Given this list of marker genes NAB1, DCLK2, INCENP, EIF2AK2, NUF2, TOP2A, PLXNB2, PLK2 (polo like kinase 2), GAD1, TOX (thymocyte selection associated high mobility group box), HCK, EHD4, GRHL1, RAD54L, KNTC1, NDFIP2, KIF4A, BDH2, GPX8, CASP8, NCAPH, MYBL1, PDCD1, MICAL2, LAG3, IFITM3, DST, TTK, CKS1B, TLR7, MIS18BP1, STRC, IFI16, PHACTR2, PPIC, EPCAM, CMKLR1, CCNA2, MX2, ORAI3, CCDC146 (NCBI Gene Id 57639), TNFSF4, CCNB2, GCNT1, TJP2, EIF4E3, KIF15, BIRC5, CKAP2L, TXN, CLGN, HSPA4L, HERC5, SGO1, CDCA8, CCNF, ARHGAP11A (Rho GTPase activating protein 11A), TCF19, RAD51, CDCA3, RRM2, EOMES (eomesodermin), DRAM1, RAD54B, BUB1B, CASP4 (caspase 4), CCDC136, GPSM2, GRM8, ITIH5, CFB, TFDP2, PRELID2, CDKN3, DGKG (diacylglycerol kinase gamma), SHCBP1, IL10, TPX2, SGO2, NEIL3, CD38, KIF14, NDC80, CENPF, CCNYL1, TACC3, RYK, IKZF2 (NCBI Gene Id 51173), TRIM59, XCL1, TMEM210, PTMS, CLSPN, LRATD1, ADAP1, TRPS1, CEP55, HAVCR2, CDK1, DOCK7, CEACAM1, ANLN, RGS16, NCAPG2, PLOD2, HMMR, STX7, CHST12, CDC20, MKI67, MNT, FGL2, SERPINI1, EPC2, MSL3, PLSCR1, SRGAP3, STMN1, SETBP1, NEB, OCIAD2, TEAD3, OFD1, PRR11 (proline rich 11), CHD7, KIF22, GCNT4, IFI44, BUB1, MLKL, CASP1, PRC1, ADGRG1, CADPS, RTP4, NKIRAS1, ANK3, EPHX1, LCLAT1, RSAD2, OPTN, HELZ2, GXYLT1, CDC14A, CDC25C, CD36, SPCS3, AIM2, PTPN13, OSGIN2 (NCBI Gene Id 734, oxidative stress induced growth inhibitor family member 2), ASPM, CHEK1, ATP5IF1, GZMK, XAF1, SRXN1, PHACTR4, AK3, GFPT1, IFIH1, LAT2, CENPE, PTTG1 (PTTG1 regulator of sister chromatid separation, securin), ALCAM, IFIT1, KNL1, SYCE1, ISG20, PBK, CD200R1L, WLS, NCAPG, CHST2, KIF11, HMGB2, TACC2, here is a description of the gene set: Genes up-regulated in B lymphocytes stimulated by anti-IgM: 2h versus 12h. from publication Arenzana TL, Smith-Raska MR, Reizis B (PMID 19329779) studied in species Homo sapiens The development, homeostasis and function of B lymphocytes involve multiple rounds of B cell receptor (BCR)-controlled proliferation and prolonged maintenance. We analyzed the role of transcription factor Zfx, a recently identified regulator of stem cell maintenance, in B cell development and homeostasis. Conditional Zfx deletion in the bone marrow blocked B cell development at the pre-BCR selection checkpoint. Zfx deficiency in peripheral B cells caused impaired generation of the B-1 cell lineage, accelerated B cell turnover, depletion of mature recirculating cells, and delayed T-dependent antibody responses. Zfx-deficient B cells showed normal proximal BCR signaling, but impaired BCR-induced proliferation and survival. This was accompanied by aberrantly enhanced and prolonged integrated stress response, and delayed induction of Cyclin D2 and Bcl-xL proteins. Thus, Zfx restrains the stress response and couples antigen receptor signaling to B cell expansion and maintenance during development and peripheral homeostasis. Human Gene Set: GSE13547_2H_VS_12_H_ANTI_IGM_STIM_BCELL_UP